Given this list of marker genes DAPK3 (death associated protein kinase 3), CRTC2, ATF4, CRTC3, ATF2, CREM, DDIT3, CRTC1 (NCBI Gene Id 94159), CREB3, SIK1, here is a description of the gene set: species: Homo sapiens Binding to a cAMP response element binding protein (a CREB protein). Human Gene Set: GOMF_CAMP_RESPONSE_ELEMENT_BINDING_PROTEIN_BINDING